The following is a description of a gene set: species: Mus musculus Mouse Gene Set: GOMF_STRUCTURAL_CONSTITUENT_OF_POSTSYNAPTIC_ACTIN_CYTOSKELETON The action of a molecule that contributes to the structural integrity of a postsynaptic actin cytoskeleton., and this is the list of marker genes: Actbl2, Actn2, Actg1, Camk2b, Dbnl, Acte1, Actb